Given this list of marker genes MOS, NDEL1, KASH5, ZBED3, FBXW11, SPRY2, LLGL1, KIF25, ZW10, HDAC3, SPAG5, NUMA1, CCDC66, MAPRE1, TLE6, BCCIP, LLGL2, NLRP5, ENKD1, PAFAH1B1, UBXN2B, ASPM, CFL1, DYNC1H1, ANKFN1 (ankyrin repeat and fibronectin type III domain containing 1), SPDL1, SAPCD2, MAP4, CENPA, DCTN1, SPIRE1, GPSM1, PKHD1, NDE1, INPPL1, NUSAP1, WASL (WASP like actin nucleation promoting factor), SKA3, CLASP1, MCPH1, ACTR3, SPRY1, ITGB1, NSFL1C, FMN2, SKA1, HTT, GPSM2, SKA2, PAX6, MISP, MAD2L1, CDK5RAP2, SPIRE2, KPNB1, KAT5, FGF10, DYNLT1, OOEP, MYH9, NDC80, CLASP2, ESPL1, GJA1, ACTR2, PLK1, here is a description of the gene set: Human Gene Set: GOBP_SPINDLE_LOCALIZATION studied in species Homo sapiens Any process in which is the spindle is transported to, and/or maintained in, a specific location.